Given this list of marker genes KIT (KIT proto-oncogene, receptor tyrosine kinase), here is a description of the gene set: part of: Drug resistance of KIT mutants studied in species Homo sapiens Reactome Pathway: Sorafenib-resistant KIT mutants Sorafenib is a type II tyrosine kinase inhibitor that is approved for use in hepatocellular and renal cell carcinoma. It is active against KIT receptors with mutations in the ATP-binding cleft and the activation loop, with the exception of substitutions at D816, which are resistant.